The following is a description of a gene set: Human Gene Set: GOBP_REGULATION_OF_TUBULIN_DEACETYLATION species: Homo sapiens Any process that modulates the frequency, rate or extent of tubulin deacetylation. Tubulin deacetylation is the removal of an acetyl group from a protein amino acid., and this is the list of marker genes: MAPT, PRKAA1, EP300, TPPP, FRY, PRKAA2, BEX4